The following is a description of a gene set: Abnormal female reproductive system physiology Human Gene Set: HP_ABNORMAL_FEMALE_REPRODUCTIVE_SYSTEM_PHYSIOLOGY studied in species Homo sapiens, and this is the list of marker genes: MCM9, B4GALNT1, SCLT1, PSMC3IP, BBS1, VPS13C, NR5A1, EIF2B3, PRLR, HDAC8, ATP7B, PSMD12, ERCC6, CHP1, HSF2BP, HLA-B, HTRA2, GP1BA, LMAN1, CAV1, DIAPH1, PODXL, BMP2, DHH, AGPAT2, POLR3H, THOC6, PROP1, NPHP4, BRAF, MSH4, BCOR, CAVIN1, CDKN1A, NPHP3, RTN2 (reticulon 2), PWRN1, NRAS, KPNA7, NHLH2, ARMC5, MEN1, BNC1, PDE4D, CEP164, HPS5, TACR3, EIF2B2, ESR1, TTC8, MCM8, BBS2, ITGA2B, F13A1, MAP3K1, HSD17B4, USP8, SEMA3E, PEX6, ZMPSTE24, SMARCE1, ANAPC7, CEP19, SUFU (SUFU negative regulator of hedgehog signaling), FGFR3, C14orf39, F11, WAS, TRAF3IP2, MCFD2, POF1B, PDGFB, FGB, F2, TBL1X, SRY, RRAS, OTX2, HROB, STAG3, MPV17, SMCHD1, SOS2, H6PD, CDKN1B, FGA, F7, NR0B1, HFM1, NDN, ERCC4, AARS2, GNRHR, FGFR1 (fibroblast growth factor receptor 1), CIDEC, PSMB8, IQCB1, ABCD1, NIN, WRN, CFAP418 (cilia and flagella associated protein 418), WNT4, PHKA2, ESR2, CYP19A1, PRORP, WIPF1, RAD21, ARL6, FSHR, AKT2, PRKN, MAGEL2, ITGA8, PMM2, HMGA2, WT1, MRAS, HS6ST1, SLC37A4, PTPN11, TRAF3IP1, BLOC1S5, LIG4, BSCL2, PROKR2, SMC3, SNORD116-1, GP6, CPE, CDKN2B, POLG2, RCBTB1, FIP1L1, NOBOX (NCBI Gene Id 402714), MSTO1, ITGB3, SEMA3A, IL17F, NBEAL2, BBS5, CCN2, ZFPM2, YARS1, CYP11B1, SPRY4 (NCBI Gene Id 81848), KISS1R, SNORD115-1 (NCBI Gene Id 338433), BTG4 (NCBI Gene Id 54766), PIK3CA, WWOX, PLAG1, FGG, SPATA22, FIGLA, XRCC2, DHX37, NPHP1, PAPSS2, SOST, SPRED2, GHR, CCR6, SCAPER, GNE, ROBO1, PLIN1, NIPBL, MKRN3, STAT3, SNCA, LZTR1, CCDC141 (coiled-coil domain containing 141), POU1F1, MOG, ANAPC1, SERPINE1, CLPP, DNAJC6, FOS, RASGRP2, CISD2, IFT172, CBL, P2RY11, TPM4, HPS4, SRA1, HCRT, AIRE, TAC3, AGK, OCA2, GP1BB, CDKN1C, COQ2, FMR1, BRD4 (bromodomain containing 4), SMO, VAMP7, TWNK, GDF9, SNRPN, TP53, HARS2, GPR101, RIT1, ATM, CLEC7A, RAF1, MKS1, SPIDR, LARS2, RASA2, NABP1, HJV, HERC2, PINK1, SMARCB1, ZSWIM7, IL17RD, LHB, EIF2B1, GALK1, KISS1, SOX10, NR3C1, TRMT10A, ERAL1 (Era like 12S mitochondrial rRNA chaperone 1), LEPR, DCC, SMC1A, IRF2BP2, DTNBP1, FOXA2, PLAU, DCAF17, BBIP1, CYP17A1, ERCC8, SYCP2L, STUB1, AGGF1, IGF2, TERT, HLA-DRB1, CCDC28B, NUMA1, NPAP1, NSMF, IFT27, F13B, SYNJ1 (NCBI Gene Id 8867), FCGR2C, ANOS1, PRKACG, ATRX, BBS10, POR, NPM1 (nucleophosmin 1), RRAS2, MKKS, F5, NBN, RIN2, BAP1, FAS, F8, POLG, TPR, RNF216, IL17RC, AIP, LHX4, GNAS, SETD2, DNM1L, SLC25A13, IRF5, ANTXR1, MYH9, ZNF365, DIAPH2, NUP107, ZBTB16, TBL1XR1, USP48, IKZF1, BMP6, PPARG, BBS7, LRRK2, WDPCP, CDH23, EIF2B4, FZD2, SLFN14, GATA4 (GATA binding protein 4), F10, LIPE, PARK7, CDON, TRAF7, NDNF, KASH5, GLI2, LEP, MEIOB, BLM (NCBI Gene Id 641), BLOC1S3, LMNA, UBAP1, FOXL2, KDM1A (NCBI Gene Id 23028), TRIP13, SLC29A3, MCM3AP, INVS, PRKAR1A (NCBI Gene Id 5573), BBS4, CDKN2C, PHKB, FLRT3, BMP4, RARA, FGF8, FLI1, MRPS22, FYB1, GPR161, HESX1, KRAS, TKT, SOX3, BBS12, WDR11, HLA-DQB1, FEZF1, FSHB, BBS9, CASP10, SOHLH1, IFT74, MOS, HAMP, PML, PWAR1, FGF17, TAF6, HFE, GATA3, BMPR1B (NCBI Gene Id 658), TTI2, IL17RA, GALT, SIM1, LZTFL1, HPS6, WNT7A, TRIM32, AR, AKT1, SOS1, AXL, GP9, BMP15 (bone morphogenetic protein 15), NF2, PHKG2, PCSK1, CTSH, SOX9 (NCBI Gene Id 6662), PTPRJ, CHD7, STAT5B, VWF, ALMS1, PEX1, PROK2, FANCM, WDR19, TFR2 (transferrin receptor 2), PEX10, MSH5, DUSP6, FASLG, CYB5A, TNFSF4, FBXO11, GNRH1, APOLD1, TP63, SDCCAG8, SYCE1, PNPLA6, UCHL1, BPTF, CEP290, CTDP1, GGPS1